The following is a description of a gene set: species: Mus musculus Mouse Gene Set: GOBP_REGULATION_OF_STEM_CELL_DIVISION Any process that modulates the frequency, rate or extent of stem cell division., and this is the list of marker genes: Sfrp2, Lbh, Smyd5, Mllt3, Nanog, Yme1l1, Nap1l2, Mpl, Sox17, Cdk2ap2, Ncoa3, Prdm15, Thoc5, Esrrb, Evi2b